Given this list of marker genes Vti1a, Scap, Pdcd6, Sar1a, Uso1, Sec16b, Sec22b, Pef1, Sec31a, Sec16a, Srebf2, Sec31b, Sec24b, Vma21, Stx17 (syntaxin 17), Cideb, Sec24d, Gosr2, Sec24c, Vti1b, Sec23a, Slc30a5, Sar1b, Klhl12, Srebf1, Sec23ip, Sec13, Sec23b, Sec24a, here is a description of the gene set: Mouse Gene Set: GOCC_ER_TO_GOLGI_TRANSPORT_VESICLE_MEMBRANE The lipid bilayer surrounding a vesicle transporting substances from the endoplasmic reticulum to the Golgi. species: Mus musculus